Given this list of marker genes MIR1-1, RGS9, YWHAE, CALM2, CALM1, CALM3, here is a description of the gene set: studied in species Homo sapiens Any process that modulates the frequency, rate or extent of calcium ion export across the plasma membrane. Human Gene Set: GOBP_REGULATION_OF_CALCIUM_ION_EXPORT_ACROSS_PLASMA_MEMBRANE